The following is a description of a gene set: species: Homo sapiens Prominent thoracic and abdominal veins. Human Gene Set: HP_PROMINENT_VEINS_ON_TRUNK Prominent veins on trunk, and this is the list of marker genes: ATP6V1A, ATP6V0A2, AEBP1, ATP6V1E1, PPARG (NCBI Gene Id 5468)